The following is a description of a gene set: MSH2:MSH6 (MutSalpha) binds single base mismatches and unpaired loops of 1-2 nucleotides. Human cells contain about 6-fold more MSH2:MSH6 than MSH2:MSH3 (MutSbeta), which mediates repair of larger mismatches, and an imbalance in the ratio can cause a mutator phenotype. The MSH6 subunit is responsible for binding the mismatch, which activates MSH2:MSH6 to exchange ADP for ATP, adopt the conformation to allow movement on the DNA, and interact with downstream effectors PCNA, MLH1:PMS2 and EXO1. The interaction with PCNA initiates excision of the recently replicated strand. MLH1:PMS2 has endonucleolytic activity and makes a nick that is enlarged to a gap of hundreds of nucleotides by EXO1. DNA is polymerized across the gap by DNA polymerase delta and the remaining nick is sealed by DNA ligase I. Reactome Pathway: Mismatch repair (MMR) directed by MSH2:MSH6 (MutSalpha) species: Homo sapiens part of: Mismatch Repair, and this is the list of marker genes: RPA2, RPA3, POLD3, LIG1, POLD1, RPA1, POLD4, EXO1, POLD2, MSH2, MLH1, PMS2, MSH6, PCNA